Given this list of marker genes MIR25, MIR30C1, THBS2, LAMC1, COL6A3 (NCBI Gene Id 1293), MIR30D, LAMB2, COL1A2 (collagen type I alpha 2 chain), COL5A2, THBS1, COL4A1, MIR30B, COL3A1, MIR429, COL6A1, ITGB5, MIR148B, MIR532, MIR30E, MIR92A2, MIR548AA2, FN1, ITGB6, MIR200A, MIR200B, MIR7-1, COL4A2, COL5A1, MIR141, MIR219A1, TNXB, MIR107, MIR548AA1, MIR15B, MIR589, SDC2, MIR30C2, LAMA4, ITGA1, ITGA11, COL5A3, COL6A2, MIR200C, here is a description of the gene set: Human Gene Set: WP_MIRNA_TARGETS_IN_ECM_AND_MEMBRANE_RECEPTORS species: Homo sapiens miRNA targets in ECM and membrane receptors